Given this list of marker genes Zfp84, Thap3, Prrt4, Toe1, Pramel3a, Ebna1bp2, Bet1l, Zfp202, Obscn, Med27, Pramel3b, Kctd6, Irx2, Hmgb1, Myo1f, Cdip1, Srpra, Usp29, Ifi208, Zcchc4, Tlk1, Barhl1 (BarH like homeobox 1), Kif13a, Pramel3e (NCBI Gene Id 331531), D630045J12Rik, Uba2, Lenep, Pramel3c, Dclre1c, Acvr1b, here is a description of the gene set: Mouse Gene Set: MIR_1911_3P from publication Chen Y, Wang X (PMID 31504780) studied in species Mus musculus Genes predicted to be targets of miRBase v22 microRNA mmu_miR_1911_3p in miRDB v6.0 with MirTarget v4 prediction scores > 80 (high confidence targets).